Given this list of marker genes GABARAP, FOXK2, RNU5E-6P, THADA, EPHA2, LRRC2-AS1, UCKL1 (NCBI Gene Id 54963), NOL4L, FLOT1, PRKCH, PHF1, ZC3H10, SLC12A8, FEZ2, POLDIP3, ZBTB38, SH3BP4, RN7SKP192, RGL2, PRCP, MICAL2, H2AC11, TAGLN2 (NCBI Gene Id 8407), RNU11, FCF1P7, H4C3, SIX3-AS1, RNVU1-27, LINC01719, TBL1X, TPST2, SDCCAG8, SCN5A, ANKRD1, HIVEP3, ADAMTS6, LINC00702, EHD1, AXL, ESYT1, POLR2A, DAAM1, C12orf57, RNU6-1, ENSG00000266088, NRAS (NCBI Gene Id 4893), ABCA10, H4C8 (NCBI Gene Id 8365), KRTAP2-4, CFLAR, UTRN (NCBI Gene Id 7402), LINC03108, KMT5C, CLDN2, LINC01776, RIN1, LINC01910, RNU12, CCN2, NREP, NRP1, KLF6, IER3-AS1, H2AC12, NCOR1, LINC01186, SQSTM1, NXN, ZBTB4, CCNB2P1, LINC02098, PGK1, PRR5L, KRT80, HNRNPUL1, PLAAT5 (phospholipase A and acyltransferase 5), TRBV12-2, POLR2B, ENSG00000226087, GARNL3, NFE2L2, SPINK4, TNIP1, DDAH2, RND3, RNU7-1 (NCBI Gene Id 100147744), LINC02709, FRMD6, MIR3193, FAM186A, PDZPH1P, PRRT2, HCG20, CLDN6, AFAP1, ZFPM2-AS1, CD68 (NCBI Gene Id 968), LINC02742, BAP1, SIN3B, LINC02599, ARNT2, POLA2, TRABD2A (NCBI Gene Id 129293), here is a description of the gene set: from publication Yevshin I, Sharipov R, Kolmykov S, Kondrakhin Y, Kolpakov F (PMID 30445619) Human Gene Set: PRMT5_TARGET_GENES Genes containing one or more binding sites for (PRMT5) in their promoter regions (TSS -1000,+100 bp) as identified by GTRD version 20.06 ChIP-seq harmonization. species: Homo sapiens